The following is a description of a gene set: studied in species Homo sapiens Wnt/Beta-catenin signaling inhibitors in current and past clinical trials Human Gene Set: WP_WNTBETACATENIN_SIGNALING_INHIBITORS_IN_CURRENT_AND_PAST_CLINICAL_TRIALS, and this is the list of marker genes: LRP6, CTNNB1, CREBBP, PORCN, LRP5